The following is a description of a gene set: species: Homo sapiens Human Gene Set: GOBP_DETOXIFICATION Any process that reduces or removes the toxicity of a toxic substance. These may include transport of the toxic substance away from sensitive areas and to compartments or complexes whose purpose is sequestration of the toxic substance., and this is the list of marker genes: PRKCE, S100A9, IPCEF1 (NCBI Gene Id 26034), GPX4, MGST3, PTGS1, MIR133B, UGT1A7, NFE2L2, OSCP1, MT1HL1, AQP8, TPO, SLC22A1, GPX7, GSTA1, HBD, PRDX6, AKR1B10, MT1F, MT1E, HBZ, HBG1, TXNDC17, FABP1, MT1A, SLC29A4, ALOX5AP, MIR133A1, NXN, MGST1, SOD3, MTARC2, PIM1, AKR1A1, HBA2, PXDNL, RDH11, NQO1, PRDX1, TXNRD3, KDM3B (NCBI Gene Id 51780), TXNRD2, SELENOF, GSTM2, MIR508, GSTM1, SLC22A18, BMP7, GSTZ1, CYGB (cytoglobin), MT1G, MUC2, AQP9, GPX5, ATP7B, HP, HBM, SRXN1, GSR, GSTM3, NOS3, MGST2, HBQ1, SLC15A2, RAB29, TP53INP1, CP, TXNRD1, PRDX4, GSTO2, PTGS2 (prostaglandin-endoperoxide synthase 2), RAB40B, EPX, PRDX5, SELENOT, ADH5, LPO, PXDN, GSTP1, SLC22A2, ALB, ADH4, MIR873, SLC30A1, SELENOW, MIR34B, MIR495, GPX6, PRDX3 (NCBI Gene Id 29017), UBIAD1, ESD (esterase D), MT1H, ABCB6, APOM, MIR185, MIR129-1, SESN1, AKR7A3, GPX3, ABCG1, UGT1A10, GPX1, ABCG2, SESN2, AIFM2, ATP7A, GPX2, GSTT1, PDZK1 (NCBI Gene Id 96133), SLC17A3 (solute carrier family 17 member 3), MT3, PARK7, ABCB1, HBB, FBLN5, APOE, ALDH1A1, MT1B, DHFRP1, HBG2, APOA4, HBA1 (NCBI Gene Id 3039), SLC30A10, PRXL2A, LANCL1, AMBP, MT1X, MIR451A, CLIC2, MT1DP, SLC47A1, MB, SLC39A8, MIR1-1, SLC47A2, MPO, SELENOS (selenoprotein S), RDH12, MT2A, MIR186, CD36, CCS, RALBP1, MIR326 (NCBI Gene Id 442900), DUOX1, MIR9-1, GSTK1, GPX8, CAT, LTC4S, DUOX2, GCH1, SLC11A1, GSTO1, DHFR, TXNDC2, MT4, TXN, HBE1, MT1M, PRDX2, MTARC1, SLC22A5, ABCC5, SOD2, SLC22A3, NNT, SOD1, PTGES